The following is a description of a gene set: Human Gene Set: HP_EXERCISE_INTOLERANCE species: Homo sapiens A functional motor deficit where individuals whose responses to the challenges of exercise fail to achieve levels considered normal for their age and gender. Exercise intolerance, and this is the list of marker genes: COA3, CCDC78, KCNJ3, PHKA2, SCN5A, PGK1, POLR2A, STN1, SFTPA2, PGM1, ACTC1, TRMT5, SPTB, ABCA3, TWNK, MT-TS2, SLC2A9, SFTPC, MT-CO2 (mitochondrially encoded cytochrome c oxidase II), CITED2, MT-ATP6, LAMP2, FLAD1, ATP11A, MT-TN, COL9A3, MYL4, GLA, MYPN, HINT1 (histidine triad nucleotide binding protein 1), PFKM, BCS1L (BCS1 homolog, ubiquinol-cytochrome c reductase complex chaperone), MT-TF, MT-CYB, PITX2, COQ8A, NDUFS4, COL13A1, KCNJ2, GCDH, HADHA, GJA5, TBX20, KCNJ5, ENO3, NKX2-6, SPTA1, TERC, PHKB, RSPH4A, MT-ND6 (NCBI Gene Id 4541), RNASEH1, TAFAZZIN, TLL1, POLG2, SVIL, PUS1, GATA5, PIEZO2, TOP3A, COMP, COL9A2, PHKG1, PHKG2, ISCU, MRPS2, RRM2B, COL12A1, CHCHD10, GATA6, C1QBP, MPV17, PGAM2 (phosphoglycerate mutase 2), SCN1B, BVES, GYPC, MUC5B, KBTBD13, EPB41, DSP, PNPLA2, KCNE2, MIEF2 (NCBI Gene Id 140774), ACAD9, PARN, HADHB, PHKA1, SURF1, TTN, KCNE1, AGK, RSPH9, ATP5F1A, NPPA, DMD, MT-CO3 (mitochondrially encoded cytochrome c oxidase III), TERT, DNA2, TMEM126B, PYGM, CAVIN1, SLC18A3, MT-TE, MT-TH, PYGL, FAM13A, KCNQ1, CPT2, TPM2, ACTA1, ATPAF2, NKX2-5 (NK2 homeobox 5), NUP155, ABCC9, OBSCN, GMPPB, BICD2, TK2, FARSA, ALDH4A1, KLHL41, COL9A1, YARS2, ATP5F1E, SFTPA1, SLC22A12, MYH6, MT-ND1, NEB, GAA, TPM3, MT-TL1, MT-ND4, MT-ATP8, FARSB, MT-ND5, RTEL1, GYS1, SCN4B, SLC25A4, ATP5F1D, SCN2B, MT-TQ, SCN3B, MGME1, MLIP, MT-TW, MT-CO1, MT-TK, SDHA, ATP5MK, KCNA5, LDHA, GATA4, DPP9 (NCBI Gene Id 91039), POLG, SLC25A32